The following is a description of a gene set: species: Homo sapiens Human Gene Set: GOBP_CEREBRAL_CORTEX_GABAERGIC_INTERNEURON_DIFFERENTIATION The process in which a relatively unspecialized cell acquires specialized features of a GABAergic interneuron residing in the cerebral cortex., and this is the list of marker genes: CNTN2, NKX2-1, DRD1 (dopamine receptor D1), RAC1, FEZF2, DRD2, DLX1, ASCL1, RAC3, ARX, DLX2, LHX6